The following is a description of a gene set: Absent tibia studied in species Homo sapiens Absence of the tibia. Human Gene Set: HP_ABSENT_TIBIA, and this is the list of marker genes: LONP1, GLI3, LMBR1, DYNC2H1, PITX1 (NCBI Gene Id 5307), ATP7A, CHD7